The following is a description of a gene set: Human Gene Set: GOBP_RESPONSE_TO_LUTEINIZING_HORMONE Any process that results in a change in state or activity of a cell or an organism (in terms of movement, secretion, enzyme production, gene expression, etc.) as a result of a luteinizing hormone stimulus. studied in species Homo sapiens, and this is the list of marker genes: NPR2, EDN1, LHCGR, EDNRA, TGFBR3, TOP1 (DNA topoisomerase I), CCNA2